The following is a description of a gene set: studied in species Homo sapiens Genes linked to the ECM maintenance and angiogenesis that were changed in HT1080 cells (fibrosarcoma) over-expressing MMP14 compared to those with knockdown of the gene by RNAi. Invasion-promoting MT1-MMP is directly linked to tumorigenesis and metastasis. Our studies led us to identify those genes, the expression of which is universally linked to MT1-MMP in multiple tumor types. Genome-wide expression profiling of MT1-MMP-overexpressing versus MT1-MMP-silenced cancer cells and a further data mining analysis of the preexisting expression database of 190 human tumors of 14 cancer types led us to identify genes, the expression of which correlated firmly and universally with that of MT1-MMP (P < 0.00001). These genes included regulators of energy metabolism (NNT), trafficking and membrane fusion (SLCO2A1 and ANXA7), signaling and transcription (NR3C1, JAG1, PI3K delta, and CK2 alpha), chromatin rearrangement (SMARCA1), cell division (STK38/NDR1), apoptosis (DAPK1), and mRNA splicing (SNRPB2). Our subsequent extensive analysis of cultured cells, tumor xenografts, and cancer patient biopsies supported our data mining. Our results suggest that transcriptional reprogramming of the specific downstream genes, which themselves are associated with tumorigenesis, represents a distinctive molecular signature of the proteolytically active MT1-MMP. We suggest that the transactivation activity of MT1-MMP contributes to the promigratory cell phenotype, which is induced by this tumorigenic proteinase. The activated downstream gene network then begins functioning in unison with MT1-MMP to rework the signaling, transport, cell division, energy metabolism, and other critical cell functions and to commit the cell to migration, invasion, and, consequently, tumorigenesis. from publication Rozanov DV, Savinov AY, Williams R, Liu K, Golubkov VS, Krajewski S, Strongin AY (PMID 18519667) Human Gene Set: ROZANOV_MMP14_TARGETS_SUBSET, and this is the list of marker genes: EMILIN2, SERPINH1, GJB2, PAEP, ANKRD1, SULF2, HAS2, CALD1, CHSY1, NR3C1, COL5A1, TIMP3, P3H1, COL18A1, MATN2, PTGS1, PLOD2, HIF1A, COL4A2 (collagen type IV alpha 2 chain), TNFRSF11B, ANGPTL2, LAMA4, COL6A2, HHIP, LOXL3, COL6A1, COL4A1, LAMB1, MDK, FN1, PLXND1, EFEMP1, ERO1A